Given this list of marker genes GNAT3, LINC02147, PROX1, MPP7, LETR1, PARD6G, DSCR9, MIR200CHG, PLSCR4, TNFAIP8L3, IRAG1-AS1, LINC02145 (long intergenic non-protein coding RNA 2145), FLT4, SLC30A3, DNAJC8P2, APP-DT, GALNT16-AS1, RPL17P36, LINC01948, CCL21, PM20D1, MMRN1, CRACR2B (NCBI Gene Id 283229), ADRB2, TSPEAR, RALGAPA2, LINC00636 (NCBI Gene Id 285205), TFPI, ABCA4, CMKLR2, PLA2G4C, ELMOD1, TBX1, TP63, PLIN5, KLHL14, ART5, IL7, ZNF24TR, STAB2, here is a description of the gene set: The gene expression program underlying the specification of human cell types is of fundamental interest. The study authors generated human cell atlases of gene expression and chromatin accessibility in fetal tissues. For gene expression, the study authors applied three-level combinatorial indexing to >110 samples representing 15 organs, ultimately profiling ~4 million single cells. The study authors leveraged the literature and other atlases to identify and annotate hundreds of cell types and subtypes, both within and across tissues. Our analyses focused on organ-specific specializations of broadly distributed cell types (such as blood, endothelial, and epithelial), sites of fetal erythropoiesis (which notably included the adrenal gland), and integration with mouse developmental atlases (such as conserved specification of blood cells). These data represent a rich resource for the exploration of in vivo human gene expression in diverse tissues and cell types. species: Homo sapiens Marker genes curated from the annotated cluster as represented in the Descartes Human Gene Expression During Development database. from publication Cao J, O'Day DR, Pliner HA, Kingsley PD, Deng M, Daza RM, Zager MA, Aldinger KA, Blecher-Gonen R, Zhang F, Spielmann M, Palis J, Doherty D, Steemers FJ, Glass IA, Trapnell C, Shendure J (PMID 33184181) Human Gene Set: DESCARTES_FETAL_INTESTINE_LYMPHATIC_ENDOTHELIAL_CELLS